The following is a description of a gene set: Human Gene Set: HP_SCLERODERMA Scleroderma A chronic autoimmune phenomenon characterized by fibrosis (or hardening) and vascular alterations of the skin. studied in species Homo sapiens, and this is the list of marker genes: CLCNKB (chloride voltage-gated channel Kb), CRYAB, LBR, UROS, UROD, IGKC, IGHG2, PAH, LEMD3, LMNA, WRN, SLC12A3, SLC29A3